Given this list of marker genes ZNF423, KIAA0586, AHI1, TUBGCP6, RPGRIP1L, TCTN2, TMEM67, ARL13B, TCTN1, B9D2, TMEM231, NPHP1, OFD1, CEP104, NRAS, FAM149B1, TCTN3, ANKRD11, ARL3, PTEN, KRAS, KIF7, TMEM138, MKS1, MEIS2, CBY1, TOGARAM1, CPLANE1, HNRNPU, SC5D, ARMC9, KIAA0753, XRCC4, HYLS1, TUBGCP4, DHCR7, B9D1, PIBF1, CEP120 (centrosomal protein 120), TWIST1, CSPP1, CD96, CEP41, MAP2K1, PLK4, KATNIP, ZNHIT3, SUFU, MAP2K2, PDE6D, CUL4B, IFT74, HRAS, CEP290, TOPORS, INPP5E, TMEM216, MCOLN1, BRAF, TMEM237, TMEM218, LIG4, GATA4, CC2D2A, here is a description of the gene set: A narrowing of the biparietal diameter (i.e., of the transverse distance between the protuberances of the two parietal bones of the skull). species: Homo sapiens Human Gene Set: HP_BIPARIETAL_NARROWING Biparietal narrowing